Given this list of marker genes Jmjd6, Etf1, F10, Sts, Sumf1, Tpst1, Riox1, Rpl8, Dph5, Drg1, Ggcx, Arsb, Dhps, Drg2, Rpl27a, F9, U2af2, Dph2, Kdm8 (NCBI Gene Id 77035), Riox2, Sumf2, Rccd1, Fn3k, Proc, Jmjd4, Arsj, Rwdd1, Furin, Arsg, F2, Icmt, Dnajc24, Dph1, Rps23, Gm48551, Arsk, Eif5a, Tpst2 (protein-tyrosine sulfotransferase 2), Dph3, Gas6, Proz, Arsa, Zc3h15, Fn3krp, Dohh, Jmjd7, F8, F7, Eif5a2, Rps6, Bglap2, Ogfod1, Pros1, Arsi, Dph6, Eef2, here is a description of the gene set: Gamma carboxylation, hypusinylation, hydroxylation, and arylsulfatase activation species: Mus musculus Mouse Gene Set: REACTOME_GAMMA_CARBOXYLATION_HYPUSINYLATION_HYDROXYLATION_AND_ARYLSULFATASE_ACTIVATION